Given this list of marker genes Amotl1, Yap1, Lats1, Dvl2, Casp3, Mob1b (MOB kinase activator 1B), Ywhae, Lats2, Wwc1, Wwtr1, here is a description of the gene set: part of: Signal Transduction studied in species Mus musculus Reactome Pathway: Signaling by Hippo electronically inferred by orthology from the curated human pathway This event has been computationally inferred from an event that has been demonstrated in another species.<p>The inference is based on the homology mapping from PANTHER. Briefly, reactions for which all involved PhysicalEntities (in input, output and catalyst) have a mapped orthologue/paralogue (for complexes at least 75% of components must have a mapping) are inferred to the other species.